The following is a description of a gene set: from publication Chen Y, Wang X (PMID 31504780) studied in species Homo sapiens Genes predicted to be targets of miRBase v22 microRNA hsa-miR-4753-3p in miRDB v6.0 with MirTarget v4 prediction scores > 80 (high confidence targets). Human Gene Set: MIR4753_3P, and this is the list of marker genes: RAD51B, DAAM1, PLPPR1, MALRD1, KIAA1586, FXR2, KIAA1549L, TBX5, LPIN2, DDX31, MFSD4B, BHLHE40, EHMT1, CHRDL1, SLC5A7, PLXNA2, RPP30, B3GLCT, ITSN2, KLHL18, ZBTB34, DMRT3, PAPOLG, TOB2, PAPSS2, MSL1, CSRNP3, CAMSAP3, SLC14A2, SEMA6D, GALNT13, PCDH17, PLP1, HPRT1, FCRLA, SLC17A6, RASGRF2, PKIB, ABLIM1, MACC1, SLC5A12, SBF1, PCDHA8, CSRNP2, LRRC1, PALM2AKAP2, SNX1, BAMBI, ATF6, CPSF6, CFTR, UTP3, THAP1, PATL1 (NCBI Gene Id 219988), ZNF770, MAP3K13, CLDN19, PTBP3, SLC8A3 (solute carrier family 8 member A3), STXBP1, SOWAHC, PFKFB2, PCDHA9, ATMIN, PLXNA4, CCBE1, PCDHA4, AKIP1, TDG, NIPBL, ZFX, RBM44, CEP97, MRPL9, ACVR1C, MEF2C, DDX6, PLCL2, PDGFA, ZNF99, CDK6, ANKFY1, FLVCR2, CD47, ACER3, ZFHX4, SOCS6, GOLIM4, BLZF1, ATP6V1C1, KCNQ3, SEMG1, SENP2, XPOT, FBXO11, SPTSSB, PCDHA1, PCDHB12, USP9Y, TWIST1, NGB, MARK2, RNF213, SMARCA1, TRPM1, REST (NCBI Gene Id 5978), RALY, COL1A2, ARRDC4, RB1CC1, HEG1, DDX21, SELENOI, KAT6A, STXBP3 (syntaxin binding protein 3), PPP1R9A, PDE1C, CD2AP, SLC39A8, MAF, NEDD4L, CES2, KMT5B, KIF16B, TMEM132C, GREM2, KIF2C, PRPF38A, HIVEP2, VPS37C, RPTN, VPS13C, NMD3, WNT3, WBP2, LRIT3 (NCBI Gene Id 345193), PDZRN4, GXYLT1 (NCBI Gene Id 338841), MYCT1, CCN4, FAM53B, FYB2, ZNF317, SSR1, USP49, PLAGL2, MEF2A, CCND1, MUC21, ZNF333, PRAME, PCDHAC1, AHCY, KL, PYGO1, UNC80, AFDN, KLHDC10, HEATR4, C1RL, CTDSP1, HAND1, DNAJC3, KIF14, KLF12, IL17RD, ARID3A (AT-rich interaction domain 3A), NDNF, RAB30, PLEKHH2, SLC9A6, GAS2L3, PAPPA, ZNF610, GUCY1A2, SDHD, PSIP1, SYNJ2BP, PCDHA3, ARID5B, EPM2AIP1, ZNF287, TSC22D2, SLAIN2, CHMP7, PACRGL, GOLGA8R, ARV1, ENC1, ZWILCH, STX11, PRKAA2, PCDHA7, CLEC16A, UMPS, TMEM167B, IQGAP2, ZNF326, MEX3B, TMEFF2, P2RY12, CREG2, RASSF5, GMPR2, CREG1, ZFAND3, TET3, RAPH1, TNFSF8, SLC38A1, SPATA19, PURA (NCBI Gene Id 5813), UBIAD1, CNOT9, MYZAP, ABCD2, LSM8, CRY2, OTC, HRH1, PAK2, RBM18, PCDHA5, CXCL5 (NCBI Gene Id 6374), ZBTB20, ALDH6A1, GREB1, GREM1, DIP2C, NTRK3, LY75, SAMD13, TBL1XR1, EPB41L5, PSMB1, PLPP3, EPHA7, LCORL, ZNF90, SPP1, PLEKHG1, DPH3 (diphthamide biosynthesis 3), MLLT3, EMX2, TMEM30B, KASH5 (NCBI Gene Id 94029), OPCML, SCAI, TRPS1, RNF138, GPRASP3, ZNF80, GOLGA8T, RIMBP2, YTHDF2, ACP7, UQCR11 (NCBI Gene Id 10975), RSBN1, RNASEK, ODF2L, SEMA3C, CRH, TRIM8, NRXN1, LAMC1, MYO5A, PAK1, PIN4 (NCBI Gene Id 5303), AAK1, ZFYVE16, NHLRC2, LYRM2, KCNJ13, KIAA1217, SUPT4H1, USP37, GDA, AMD1, RGS21, SMIM10L1 (NCBI Gene Id 100129361), EDNRB (NCBI Gene Id 3282), THOC2, SI, DTNA, PAG1, ARG2, PIGN, NUDT3, LENG8, TMTC1, WDR36, UNC5D, PDLIM5 (PDZ and LIM domain 5), RAB11FIP2, PPP2R5B, RGS5, STAP1, UTRN, MCFD2, ALDH2, POSTN, PPP4R3A, CAPS2, ASH1L, PTPRB, PDE4D, HTR5A (NCBI Gene Id 3361), TASP1, CREM, HOXA3, MED20, CACNG2, MDM2, TTR, ZBTB41, ACSM2B, KLHL42, DHRS1, FABP7, PPM1L, FOXD4L5, PCDHA13, CPEB3, KCNRG, CFAP91, LYST, GIGYF2 (GRB10 interacting GYF protein 2), SIK3, IL11RA, MIPOL1, ERC1 (ELKS/RAB6-interacting/CAST family member 1), CNOT1 (CCR4-NOT transcription complex subunit 1), BLOC1S6, ATG4C, RNF169, RAB3B, PIP5K1B, PNPLA5, GALNT2, ZMYM2, FAM120A, ADAM10, CACNA1D, CCDC14, GRIP1, KDM7A, NCOA6, FAM78A, CHCHD3, PITPNC1, COG2, CRYBA4, PCDHA2, CNR1, NLGN4X, MBNL3, SERPINE1, KIF5B, AUTS2, GATC, PLEKHM3, HOXC8, FAM81A, NELL1, MAP3K5, NAV2, PNPT1, BTBD1, BCL11A, LARP4, MAGI1, KITLG, GPR158, HEPACAM, POU2F1, ST3GAL5, PPP1R15B, GRP, PRDM16, TSHR, SLC35F3, TET2, LAMB4 (laminin subunit beta 4), SLK, ST6GALNAC5, FBXL17, PCDHA11, SGMS1, CGNL1, LRRC66 (NCBI Gene Id 339977), PRDM10, TENM1, GRAMD1B, GALR1, FLCN, TTC14, GALNT14, POU2F2, RALB, APBB2, RBM20, LINGO1, CCDC126, SLC7A14, IKZF5, RALGPS2, ATG5, SLCO1B3, TMTC3, SLFN13, MERTK, MPDZ (NCBI Gene Id 8777), ACOT8, DGKH, CPNE6, PROK2, NSL1, EDIL3, BACE1, PRIMA1, FCRL4, PPARGC1A (NCBI Gene Id 10891), TMEM260, TSPAN2, PTER, MEX3C, ZNF138, MRPL33, CASK, YPEL2, SHLD2, COX11 (cytochrome c oxidase copper chaperone COX11), EHD4, TRIO, PHACTR2, PLAA, NAA50, LINC02907, SPDYE6, PDGFRA, ALDOB, ATXN7, WBP1, B4GALT6, AIMP1 (aminoacyl tRNA synthetase complex interacting multifunctional protein 1), TNF, ZNF566, OGN, RNF217, PCDHB4, TMEM87A, SH3KBP1, NETO1, SPTBN1, RPS10-NUDT3, SYT4, DPP10, IKZF2 (NCBI Gene Id 51173), ANO5, PPP2CB, PCDHA10, TNRC6B, RAB7A, SNX14, CXCL3, WDR91, ARHGAP28 (Rho GTPase activating protein 28), PDE11A, LPP, TFDP1, CTDSPL2, COL11A2, EIF2S1, YWHAB, TEAD1, TLE1 (TLE family member 1, transcriptional corepressor), ZNF268, ONECUT2, TMEM165, SP3, RPIA, IGF2BP2, MRPL19, C11orf54, PATL2, ZEB2, UBN2, CD86, IQUB, DCX, CDK12, GSK3B, PHF1, GOLGA8Q, LRRC58, KCNN3, CELF2, ZNF385D, PIK3R1, NCKAP5, PHLDB2, GIPC2, RHOA, ZNF514, XPO4 (NCBI Gene Id 64328), MTARC2, MS4A2, ZNF704, NOVA1, PDHA2, OSER1, FGD6, DES, ZNF682, CD28, GOLGA8J, INPP5A, GAD1, BNC2, DSCAM, PDZD2, SYT1, ABI3BP, ACSM2A (NCBI Gene Id 123876, acyl-CoA synthetase medium chain family member 2A), GIN1, RORA, SLC1A1, ZC2HC1A, TRIM71, WASHC4, ALKBH8, VPS33A, DPY19L2, UBE2D2, GLIPR1, POLR3B, ARHGAP24, PTBP1, CPEB2, PRKACA, STK38, PCDHA12, SOBP, YIPF5, FZD10, ELAVL1, TMEM35A, MYH9, COPG2, FZD2, PARP15, CCNJ, KIAA0513, TBC1D8B, PCDHA6, PDCD6IP, HUS1, PCDHAC2, EXTL3